Given this list of marker genes SLC2A3, ETF1, NME1, HROB, RAD23B, FOXH1, DDX46, GPATCH4, PDAP1, TCERG1, PMPCA, G3BP2, TACR3, NIFK, SMS, SSH2, RBM8A, ATP5MC1, HNRNPDL, RRAS2, UHRF1, GDAP1, ADSS2, PMF1, MEMO1, SMN1, TOMM70, POLE3, TNFRSF13B, RBMX, TLCD3A, PEX19, FUS, GIT1, EIF1AX, BRI3BP, HSPD1, TIMELESS, BZW1, NOL11, RPS6KA5, KCNG1, MTFR2, PA2G4, SIGMAR1 (sigma non-opioid intracellular receptor 1), UTP20, GOSR2, PACSIN2, BRINP1, FKBP5, BLMH, HARS1, TSR2, SHMT2, ERH, SNAPC1, FAM107B, SF3A3, LYRM4, SF3A1, TPI1, EXOSC9, DOK1, IFITM1, SSR1, PSMC5, RCC1L, TMEM106B, NOP16, ADPRH, SLC27A1, PPAT, ARHGAP1, GTF2F1, CENPT (NCBI Gene Id 80152), PPRC1, UBE2M, L3MBTL2, NDRG1, CCNE1, CDC7, CPSF4, DNAJC16, GAR1, HSPA4, ELP3, DDX1, AHCY, ING5, API5, STARD7, CD300LF, ARID3A, ZAR1L, PPP2R5B, SYNGR2, CPSF6, DCAF12L2, PDXK, AARSD1, IFITM2, NCOA5, ACTR1A, RARS1, ZBTB7A, GALNT4, TRAPPC10, CAND1, TNFSF11 (NCBI Gene Id 8600), SHMT1, COPS7B (NCBI Gene Id 64708), DNAJA2, TTLL12, SLC25A51, UTP25, DEPDC1B, CIRBP, DYTN, MYC, MIER1, DESI2, CAB39, ESM1, RPF2, LRPPRC, SDHD, ANKRD50, URM1, HAUS4, MS4A4A, SEPTIN2, ACP1 (acid phosphatase 1), NEFL, GSTM4, RBM41, BANF1, MED18, DDX52, SDAD1, POLR3D (NCBI Gene Id 661), MTX1, EID1, PPIE, TBRG4, POLR3F, POLR1A, DAPL1, WDR5, PRDM1, SMAP2, N4BP2, BCO2, MTMR1, KCNJ2, BUD13, GMPS, PRMT5, PLAA, PRPF3, COX10, MATR3, PES1, NOP2, ROMO1, HSPA9, WDR76, PDHX, DTD1, COMMD8, RNMT, DDX21, FBXW8, here is a description of the gene set: Human Gene Set: GSE14415_TCONV_VS_FOXP3_KO_INDUCED_TREG_UP The gene expression profile of peripheral Foxp3+ natural regulatory T cells isolated from Foxp3/EGFP bicistronic mice was compared to that of in vitro-induced regulatory T cells and to CD4+ conventional (Foxp3-) T cells. The role of the regulatory T cell transcription factor Foxp3 in shaping the transcriptosomes of natural and induced regulatory T cells was analyzed using mice expressing a mutant FOXP3-EGFP fusion protein (Foxp3deltaEGFP). We used gene expression microarrays to examine the transcriptional programs of natural and induced regulatory T cells and the function of Foxp3 in organizing the transcriptosomes of the respective cell type species: Homo sapiens Genes up-regulated in T conv versus induced T reg with non-functional FOXP3. from publication Haribhai D, Lin W, Edwards B, Ziegelbauer J, Salzman NH, Carlson MR, Li SH, Simpson PM, Chatila TA, Williams CB (PMID 19265124)